Given this list of marker genes FGFR3, here is a description of the gene set: studied in species Homo sapiens In recent years, recurrent fusions of FGFR3 have been identified in a number of cancers, including glioblastoma and cancers of the lung and bladder, among others. The most common fusion partner of FGFR3 is TACC3 (transforming acidic coiled coil protein 3), a protein involved in mitotic spindle assembly and chromosome segregation. FGFR3 fusions are constitutively active and may form oligomers in a ligand-independent manner based on dimerization domains provided by the fusion partner. Transformation and proliferation appear to be promoted through activation of the ERK and AKT signaling pathways. In contrast, PLC gamma signaling is not stimulated downstream of FGFR3 fusions, as the PLC gamma docking site is not present in the fusion. FGFR3 fusions are sensitive to protein kinase inhibitors, suggesting their potential as therapeutic targets. Reactome Pathway: Signaling by FGFR3 fusions in cancer part of: FGFR3 mutant receptor activation